The following is a description of a gene set: Mouse Gene Set: GOBP_NEGATIVE_REGULATION_OF_MAPK_CASCADE studied in species Mus musculus Any process that stops, prevents, or reduces the frequency, rate or extent of signal transduction mediated by the MAPKKK cascade., and this is the list of marker genes: Ptpn6, Dusp9, Cdk5rap3, Spred1, Rapgef1, Abca7, Sirt3, Ptpn2, Uchl1, Dusp6, Zmynd11, Klf4, Dmd, Rnf149, Eif3a, Ptpn22, Flcn, Tnip1, Vrk3, Cdc42se1, Prdm15 (NCBI Gene Id 353037), Smad4 (SMAD family member 4), Irak3, Dusp5 (dual specificity phosphatase 5), Nlrp12, Dok1, Hipk3, Tlr9, Ezr, Cav1, Emilin1, Phb1, Gstp1, Dab2ip, Fbln1, Apc, Ptprc (NCBI Gene Id 19264), Wnk2 (NCBI Gene Id 75607), Bmp2, Cd300a (NCBI Gene Id 217303), Sfrp1, Btn2a2, Dusp4, C1ql4, Synj2bp, Sfrp4, Chrna10, Paqr3, Sema6a, Dab2, Dusp2, Nup62, Klhl31, Cav3, Tlr4, Cyld, Gps2 (G protein pathway suppressor 2), Dusp7, Nf2, Psmd10, Ash1l, Sh3rf2, Ankrd26, Sirpa, Efna1, Lilrb4b, Dusp10 (dual specificity phosphatase 10), Prkn, Lilrb4a, Pebp1 (phosphatidylethanolamine binding protein 1), Abl1, Taok3, Spry4, Csk, Men1, Errfi1, Dnaja1, Pik3r2, Chrna7, Nppa, Itgb1bp1, Cryba1, Lmo3, Pdcd4, Dag1, Pea15b-ps, Apoe, Atf3, Ranbp9, E130311K13Rik, Lif (NCBI Gene Id 16878), Lax1, Ptprj, Rps6ka6 (NCBI Gene Id 67071), Trem2, Dynlt1b, Ncor1, Prkcd, Ppia, Foxo1, Chrna9, Dact1, Nherf1, Sbno1, Fem1a, Ndrg2, Gba1, Pin1rt1, Inpp5k, Dsg3, Tbc1d10c, S2bpcox16, Dusp13b (NCBI Gene Id 382853), Pbk, Lemd2, Ephb2, Spred3, Psca, Igf1, Pik3cb, Pp2d1, Hmgcr, Dusp19, Spry1, Cnksr3 (Cnksr family member 3), Mapk8ip1, Il1b, Xbp1, Fktn, Styxl2, Dusp3, Aida, Phlpp1, Spred2 (NCBI Gene Id 97717), Cblc, Arrb1 (NCBI Gene Id 74110), Dusp8, Ppef2, Per1, Epha4, P2rx7, Dok2, Dusp16, Itch, Smpd1, Prmt1, Nf1, Gstp2, Pafah1b1, Akt1, Ace2, Pin1, Mecom, Sfrp5, Ptpn1 (protein tyrosine phosphatase, non-receptor type 1), Sfrp2, Hyal2, Pparg, Prkca, Dusp26, Pbp2, Sh2b3, Gper1, Foxm1, Igf1r, Rgs2, Dusp29, Marveld3, Stk38, Lyn, Hdac3, Agt, Adipoq, Nlrp6, Spry2, Dusp1, Gstp3, Qars1, Ptprr, Gstp-ps, F2rl1, Dlg1, Rgs14